The following is a description of a gene set: studied in species Homo sapiens part of: Metabolic disorders of biological oxidation enzymes The UDP-glucuronic acid/UDP-N-acetylgalactosamine transporter (SLC35D1) is an ER membrane-spanning protein that transports nucleotide-sugars from the cytosol into the ER lumen. SLC35D1 transports UDP-GlcUA and UDP-GalNAc, which are substrates for the synthesis of chondroitin sulfate disaccharide repeats, suggesting a role in chondroitin sulfate biosynthesis. Mutations in SLC35D1 can cause Schneckenbecken dysplasia (SCHBCKD; MIM:269250), a rare, autosomal recessive, lethal short-limbed skeletal dysplasia affecting cartilage and skeletal development. Reactome Pathway: Defective SLC35D1 causes SCHBCKD, and this is the list of marker genes: SLC35D1